The following is a description of a gene set: part of: Defective homologous recombination repair (HRR) due to BRCA2 loss of function Reactome Pathway: Impaired BRCA2 binding to SEM1 (DSS1) species: Homo sapiens This pathway describes BRCA2 cancer mutations that affect the ability of BRCA2 to bind to SEM1 (DSS1), a small protein of 70 amino acids that regulates BRCA2 stability and its nuclear localization., and this is the list of marker genes: SEM1, BRCA2